The following is a description of a gene set: Human Gene Set: HP_CHRONIC_PAIN Chronic pain studied in species Homo sapiens Persistent pain, usually defined as pain that has lasted longer than 3 to 6 months., and this is the list of marker genes: SMCHD1, FLVCR1, ZFX, MMP1, DUX4L1, COL7A1, ATXN3, TGFB2, CTSK, DUX4, FRG1, DNMT3B